Given this list of marker genes Med15, Med6, Med9, Psmc6, Med18, Ikzf1, Smarcb1, Med23, Esr1, Taf1b, Med30, Taf7 (TATA-box binding protein associated factor 7), Taf8, Brf2, Taf1c, Dr1, Med21, Thra (thyroid hormone receptor alpha), Taf9, Med27, Med31, Cand1, Taf6l, Polr1e, Taf2, Med17, Med24 (mediator complex subunit 24), Taf12, Bdp1, Med11, Taf11, Med14, Med10 (mediator complex subunit 10), Taf5, Taf13, Brf1, Gtf2a1, Med4, Taf10, Med19, Gtf2f2, Taf6, Gtf2b, Hmgb1 (NCBI Gene Id 15289), Med7, Gtf2a2, Med16, Creb1, Med8, Med22, Med1, Med25, Taf4, Trp53 (transformation related protein 53), Rrn3, Ahr, Taf7l, Taf1, Med20, Wnt10b, Tbp, Med28 (mediator complex subunit 28), Med26, Taf4b, Med29, Taf3, Nfkbiz, here is a description of the gene set: Mouse Gene Set: GOBP_TRANSCRIPTION_PREINITIATION_COMPLEX_ASSEMBLY The formation of a large multiprotein-DNA complex that self-assembles on gene promoter through the sequential recruitment of the general initiation factors that compose the preinitiation complex (PIC). The PIC engages the RNA polymerase on its DNA template strand and sparks polymerization of the first few RNA nucleotides. studied in species Mus musculus